The following is a description of a gene set: Mouse Gene Set: GOBP_PROSTATIC_BUD_FORMATION species: Mus musculus The morphogenetic process in which a region of the fetal urogenital sinus epithelium is specified to become the prostate, resulting in prostate bud outgrowth., and this is the list of marker genes: Trp63, Wnt5a, Shh, Bmp7, Gli2, Sulf1, Bmp4, Fgf10, Ar, Nog